Given this list of marker genes CTNND1, ZNF627, ABCA11P, ZNF24, CREG1, SCML1, DUS4L, GALNT12, DDC-AS1, ADGRG5, C9orf40, FCGBP, GSTM1, ZC3H14, SPTBN1, CLTRN, GRB10, LEF1, THUMPD1, RAPH1, TP53AIP1, NFRKB, MLLT3, SNORD104, CHMP4B, RBIS, CNRIP1, PIGP, HMGA1, DUSP5P1, MMP27, DNAJC6, FHIT, PDIA5, MATCAP2, ENSG00000280119 (NCBI Gene Id 650036), GGNBP2, TBC1D23, ZNF18, SPON1, PRKAG2, HIF1A, CPLANE1, DNTT, ARMCX1, LRP6, UQCC1, ZNF397, C20orf141, TLR2, SLC22A23, TMEM71, GGPS1, DRICH1, SNHG17, AMDHD1, POU6F1, D2HGDH, SRBD1, TOP1MT, ZNF30, CASP10, EIF2B3, ZIK1, TMEM39B (transmembrane protein 39B), HARS1, TRABD2A, THYN1, NET1, STX3, OR7E47P, PDE7B-AS1, PRKCA, ATP1A1, MIR101-1, SNHG7, CRTAM, GVINP1, TCF7L2, LUM, TMEM25, SLC40A1 (NCBI Gene Id 56414), COQ10A, CELA1, ATP6V1G2, ADAMTS10, SVIL, H2BC21, TMEM150A, KISS1R, STIM2 (stromal interaction molecule 2), STX17, HMGN3, DPY19L4, SNTB1, METTL16, PLLP, TAS2R4, NOSIP, C1orf162, PRKAG2-AS1, RIPOR2, SLC20A1, SMIM19, CBY1, SECTM1, HEBP1 (heme binding protein 1), FOXJ3, TNFAIP8, C1orf115, CLIC6, URI1, MYH3, CCNK, LGALS3BP, PLAC8, ZNF677, EIF4G1, GOLGA7B, VENTXP1, PPP2R3A, PTH2R, ADPRM, PLEKHG6, TMEM131L, RPS20, CCNG1, C6orf136, ADPRHL1, KLHDC1, TMEM170B, BTBD8, HHLA2, TMEM177, TTC4 (NCBI Gene Id 7268), TMED10, HEMGN, UBE2E2, EDAR, ZNF439, CNIH4, USP51, RIMKLB, ORC5, BCR, SPINT2, CTSL, IGIP, SSBP2, ZNF493, CTTN, APP, POLR3D, DCTN5, EIF1AX, CD34, LRRC74B (leucine rich repeat containing 74B), RBM20, BBS12, TNFRSF10B, AARSD1, ZNF629, RAB43, ACSM3, ENSG00000291179, STXBP1, JMJD8, SH3RF3, PMEPA1, MXI1, MICU3, SERPINA5, ST7L, SLC22A24, MSH6, METAP1D, SH3BGR, OCRL, FMNL3, NFIA, MT1X, CTSF, NUB1, TBC1D12, NDP, PDE4D, TSPAN6, RAB9B, LMLN, SEC14L1P1, LRRN3, here is a description of the gene set: Human regulatory T cells (TR) cells have potential for the treatment of immune mediated diseases, such as graft versus host disease, but the anergic phenotype of these cells makes them difficult to expand in vitro. We have examined the requirements for growth and cytokine expression from highly purified human TR cells, and correlated these findings with the signal transduction events of these cells. We demonstrate that these cells do not proliferate or secrete IL-10 even in the presence of high doses of IL-2. Stimulation with a superagonistic anti-CD28 antibody (clone 9D4) and IL-2 partially reversed the proliferative defect, and this correlated with reversal of the defective calcium mobilization in these cells. Dendritic cells were effective at promoting TR cell proliferation, and under these conditions the proliferative capacity of TR cells was comparable to conventional CD4 lymphocytes. Blocking TGF-beta activity abrogated IL-10 expression from these cells, while addition of TGF-beta resulted in IL-10 production. These data demonstrate the ability of dendritic cells to provide proper costimulation to overcome the anergic phenotype of TR cells. In addition, these data demonstrate for the first time that TGF-beta is critical to enable TR cells to express IL-10. from publication Bonacci B, Edwards B, Jia S, Williams CB, Hessner MJ, Gauld SB, Verbsky JW (PMID 22562448) studied in species Homo sapiens Genes down-regulated in comparison of regulatory T cell (Treg) versus conventional T cells. Human Gene Set: GSE22045_TREG_VS_TCONV_DN